Given this list of marker genes Tbx1 (T-box 1), Klhl40, Hdac4, B4galnt2, Col6a1, Fkrp, Large1, Cyp26b1, Hdac9, Ppif (NCBI Gene Id 105675), Hdac5, Nln (NCBI Gene Id 97876), Six4, Shh, Fktn, Rbm24, here is a description of the gene set: Mouse Gene Set: GOBP_SKELETAL_MUSCLE_FIBER_DIFFERENTIATION The process in which a relatively unspecialized cell acquires specialized features of a skeletal muscle fiber cell. Skeletal muscle fiber differentiation starts with myoblast fusion and the appearance of specific cell markers (this is the cell development step). Then individual skeletal muscle fibers fuse to form bigger myotubes and start to contract. species: Mus musculus